Given this list of marker genes Stat5a, Mapk3, Stat5b, Ptpn1, Gh, here is a description of the gene set: part of: Cytokine Signaling in Immune system This event has been computationally inferred from an event that has been demonstrated in another species.<p>The inference is based on the homology mapping from PANTHER. Briefly, reactions for which all involved PhysicalEntities (in input, output and catalyst) have a mapped orthologue/paralogue (for complexes at least 75% of components must have a mapping) are inferred to the other species. studied in species Mus musculus Reactome Pathway: Growth hormone receptor signaling electronically inferred by orthology from the curated human pathway